Given this list of marker genes PRKN, ITPR1, ITPR2, PLCG1, ITPR3, here is a description of the gene set: Pathway Definition from KEGG: PRKN* -> PLCG1 -> IP3 -> ITPR -> Ca2+ species: Homo sapiens Mutation-inactivated PRKN to mGluR1 signaling pathway. Pathway ID: N01032. Pathway type: Variant. Pathway class: nt06463 Parkinson disease. Human Gene Set: KEGG_MEDICUS_VARIANT_MUTATION_INACTIVATED_PRKN_TO_MGLUR1_SIGNALING_PATHWAY